Given this list of marker genes SUMO2, PGR, HDAC4, RXRA, NR1H4 (NCBI Gene Id 9971), NR1I2, RORA, PPARG, PIAS4, SUMO3, NR3C1, VDR, RARA, AR, ESR1, PIAS2, PIAS3, THRA, SUMO1, PPARA, THRB, NR3C2, NR2C1, NR5A2, NR1H2, UBE2I, NR5A1, NR4A2 (nuclear receptor subfamily 4 group A member 2), NR1H3 (NCBI Gene Id 113429), PIAS1, here is a description of the gene set: Reactome Pathway: SUMOylation of intracellular receptors At least 17 nuclear receptors have been discovered to be SUMOylated. In all but a few cases (notably AR and RORA) SUMOylation causes transcriptional repression. Repression by SUMOylation is believed to occur through several mechanisms: interference with DNA binding, recruitment of corepressors, retention of corepressors at non-target promoters (transrepression), re-localization of nuclear receptors within the nucleus, interference with dimerization of receptors, and interference (crosstalk) with other post-translational modifications. SUMOylation of receptors affects inflammation and disease processes. studied in species Homo sapiens part of: SUMO E3 ligases SUMOylate target proteins